Given this list of marker genes RPL13A, UBD, CES1, AKR1C1, FST, HLA-C, UGT1A8, CD14, GLUL, SPINK1, CHI3L1, PRDX1, DPYD, DUSP22, DPP4, HLA-DRB3, GGH, SPP1 (NCBI Gene Id 6696), A1CF, MALAT1, CD74, ACTB, FGB, SLC25A5, FABP1, FTH1, MRFAP1, FGA, PTGR1, MYL6, REG3A, REG1A, here is a description of the gene set: Human Gene Set: CAVARD_LIVER_CANCER_MALIGNANT_VS_BENIGN Genes identified by subtractive hybridization comparing malignant and benign components of a hepatocellular carcinoma (HCC) in a pre-existing liver adenoma in a morphologically normal liver. studied in species Homo sapiens The Wnt/beta-catenin signaling pathway is activated in many human hepatocellular carcinomas (HCC). We tried to identify the genes involved in carcinogenesis and progression of HCC with beta-catenin mutations. We used PCR-based subtractive hybridization to compare gene expression between malignant and benign components of a human HCC occurring in pre-existing adenoma activated for beta-catenin. Two of the genes identified belong to the Regenerating gene (REG) family. They encode the Regenerating islet-derived 3 alpha (REG3A/HIP/PAP/REG-III) and 1 alpha (REG1A) proteins, both involved in liver and pancreatic regeneration and proliferation. Using siRNA directed against beta-catenin, we demonstrated that REG3A is a target of beta-catenin signaling in Huh7 hepatoma cells. The upregulation of REG3A and REG1A expression is significantly correlated to the beta-catenin status in 42 HCC and 28 hepatoblastomas characterized for their beta-catenin status. Thus, we report strong evidence that both genes are downstream targets of the Wnt pathway during liver tumorigenesis. from publication Cavard C, Terris B, Grimber G, Christa L, Audard V, Radenen-Bussiere B, Simon MT, Renard CA, Buendia MA, Perret C (PMID 16314847)